Given this list of marker genes CDC42BPG, HEXB, C5orf63, PLPP1 (NCBI Gene Id 94702), ZNF213, NFKBIE, KBTBD7, GALNS, SH3TC1, LTA, CKAP2L (cytoskeleton associated protein 2 like), TXNDC11, DNASE1L2, SLC39A13, CRISP3, REEP5, COPRS, KCNJ1, OPTN, ZFP90, TSC1, CD86, POLD1, GXYLT1, ZNF768, OOSP2, BIN1, PRRC1, ZNF710, PCK2, ZNF239, COQ7, MCAM, ARPC5L, CHCHD10, TMEM131L, CCDC122, TOX2, LITAF, DHX57, DSTYK, CRYZ, ALOX5AP, SNX9, CSRNP1, SLC51A, CCDC9, RIDA, ZFP36L1, SGO1, TP53INP2, ZNF667, TOMM6, SNX13, SLC29A3, DRAM2, SH3BGRL, RASSF4, EXOC6, RHOBTB1, ZC2HC1A, APOBEC1, ZBTB20, HCAR1, MAP3K5, ST14, ATP6V0B, TMEM242, TEP1, PHTF2, MAP3K1, SERINC3, HSPA2, PCYOX1, PCDH18, P2RY10, MYO18A, PGGT1B, H1-0, PPWD1, TBC1D9, LYNX1, YWHAE, ATL1, KANSL2, AMOT, TANK, SLC35F5, BMP2K, INPP5F, SRSF10, POMT1, LHFPL2, HSPA4, TERF2, LPGAT1, ACSL1, PIK3AP1, RFTN1, PTGIR, FAM83E, CWC27, CHST1, HIF1A, RAPGEF3, DENND6A, WDR11, RNPC3, CYTL1, SIX3, ROGDI, PTPN14, QKI, CLIC4, ASB1, SESN3, NAAA, ANKRD24, MKI67, BEND5, DCBLD1, PRNP, EIF2AK3, PRKCI, CSF2RB, SPC24, HLA-DMA, SH3BP2, BFSP2, MCM5, MCCC2, PARP3, C11orf54, IRAK2, MDFIC, NDE1, CEP89, SUMF1, PLEKHM1, TVP23A (NCBI Gene Id 780776), PTPN6, TASL, IFITM3, ANXA1, FAM204A, ADM, PRKAB2, PTGR1, MYADM, SPAG9, CAPN5, RAD17, MYOM1, AKAP7, CYFIP1, TPX2, FCHSD2, ERCC6L, NLRP12, OAS2, CFAP126, GNAZ, RARRES1 (NCBI Gene Id 5918), SPON2, CTNND1, CYP27A1, ENPP1, SMAD2, BRWD1, ARID4A, BLOC1S2, CAT, ABCA5, BAZ2B, CTH, TSPAN2, PCLAF, BCL2L2, DNASE1L3, ZNF518B, PBX3, CNNM2, VWCE, TMEM168, SLC25A19, GTDC1, JMJD1C, DPF3, PCBP1 (poly(rC) binding protein 1), CEBPZOS, STRADB, GNGT2, PTGR2, PCP4, KTN1, CASP7, BUB1B, TXNDC16, INSR, DNTTIP2, here is a description of the gene set: from publication Kaji T, Ishige A, Hikida M, Taka J, Hijikata A, Kubo M, Nagashima T, Takahashi Y, Kurosaki T, Okada M, Ohara O, Rajewsky K, Takemori T (PMID 23027924) studied in species Homo sapiens Human Gene Set: GSE11961_GERMINAL_CENTER_BCELL_DAY7_VS_PLASMA_CELL_DAY7_DN Genes down-regulated in day 7 germinal center B cells versus day 7 plasma cells. To obtain insight into the genetic basis of the increase of functional activity of memory B cells over time, we compared the gene expression profiles of day 7 and day 40 NP-specific/IgG1 memory B cells, GC B cells and plasma cells in immunized WT mice and naïve B cells, before and after activation in vitro.